The following is a description of a gene set: Joining of the large ribosomal subunit with the translation preinitiation complex, with release of IF2/eIF2 and IF3/eIF3 or IF5B/eIF5B. This leaves the functional ribosome at the AUG, with the methionyl/formyl-methionyl-tRNA positioned at the P site. studied in species Mus musculus Mouse Gene Set: GOBP_FORMATION_OF_CYTOPLASMIC_TRANSLATION_INITIATION_COMPLEX, and this is the list of marker genes: Eif3i, Eif3h, Eif3m, Eif3l, Eif3e, Eif3d, Eif3b, Eif3j2, Eif3j1, Eif3g, Eif3a, Eif3k, Eif3c, Eif3f (NCBI Gene Id 66085), Eif5